Given this list of marker genes AHCYL2, LRRC32, CDCA7, NPM1, IFT80, SLC4A7, TMEM109, TAGAP, SLC16A6, LANCL2, MID2, LARP1B, PTPN4, KIAA1958, ITGB8, RBM45, HELLS, ADAM9, RORA, CD38, SMC4, PTGES3, ENTPD1, PKP4, AMPH, MGST2, PIP5K1B, NEFH, MYO5A, SLC25A24, FNBP1, BMP7, CD200, VWA5A, RUNX2, TMEM154, MGAT5, SLAMF1, PCGF2, WDHD1, SCAMP1, CPQ, CHCHD10, PDK3, MYO18A, CALM1, HOPX, ATP9A, CSF1, NSMF, ATL3, SFXN1 (NCBI Gene Id 94081), CES2, PLA2G6, SWAP70, ACADS, NR3C2, AGFG1, SMYD2 (SET and MYND domain containing 2), SLC2A3, DSCAM, NRP1 (neuropilin 1), TMED7, TTC39B, PPP2R5C, CORO1B, PTPN13, CPE, WDR83OS, CNTLN, YWHAB, USP1, MIF (macrophage migration inhibitory factor), CYTH4, SH2D2A, CAPZA1, ANKRD55, LRRC61, GRIK5, CD37, PLCL1, FCRL1, FAM124B, DST, VPS28, TBC1D4, GSTA4, ZDHHC2, TIAM1, GATA1, TRIM35, CATSPERD (cation channel sperm associated auxiliary subunit delta), MYO1F, DTL, CEMIP2, DDIAS, ABI2, PTPN22, CD84, YBX1, CSTPP1, ETFBKMT, SLC12A2, SOCS5, SERPINC1, EPCAM, TDRD3, PLCB3 (NCBI Gene Id 5331), PLXNA3, PTPRVP, KLK8, PTBP1, TANK, TWSG1, REXO2, ACOT9, SUMO2, EIF4E, PLEKHA8, REPS1, PLP2, NUCB2, KLF12, TNFSF10, MSANTD4, MCTP1 (multiple C2 and transmembrane domain containing 1), NEB, CRYZL1, PARVG (NCBI Gene Id 64098), GNAQ, KCNA3, VAV2, KCNA2, SH3RF1, TFDP2 (transcription factor Dp-2), HEMK1, PLAGL1, LMAN1, ENDOD1, DPP4, ADAMTS6, SRSF10, PHTF2, PTMS, SAMSN1, NT5E, LCP1, SUSD2, RHOH (NCBI Gene Id 399), HACD3, NCKAP1, UBASH3B, ARHGAP25, CXCR3, GZMB, POLM, DUSP4, GNAI3, ALAS1, LGALS8, NRN1, NEBL, NEK7, RNPEP, ST6GALNAC3, MATN2, SLC66A3, EGR2, PEAR1, CD79B, GDI2, IL9R, LY96, PLXNC1, RASSF4, F2R, PRDM1, PLCD1, P2RX7, CDC42BPB, TRDN, CD22, RNF216, FAM111A, PTGER4, COPS2, here is a description of the gene set: from publication Zhu Y, van Essen D, Saccani S (PMID 22633489) Genes up-regulated in dendritic cells: unstimulated versus LPS. studied in species Homo sapiens In dendritic cells, expression of the H3K9me3 demethylase JmjD2d is upregulated by LPS stimulation. To identify genes whose induction by LPS depends on JmjD2d activity, we performed a microarray analysis of wild-type and JmjD2d-knockdown dendritic cells, before and after stimulation with LPS. Human Gene Set: GSE32255_UNSTIM_VS_4H_LPS_STIM_DC_UP